Given this list of marker genes KRT71, DES, KRTAP9-7, KRTAP4-12, NCKIPSD, SYNM, BBLN, KRT39, KRT87P, VMAC, KRTAP4-5, KRTAP20-4, SAP30BP, PRKCE (protein kinase C epsilon), SYCE1L, HOXA13, GPER1, KRTAP23-1, DLGAP2, SMARCA2 (NCBI Gene Id 95083), KRTAP10-2, NARF, DSP, CLIP1, KRT23, KRTAP20-3, IFFO2, HLA-DRB1, KRTAP26-1, KRT31, PFDN5, KRT72, TLK2, KRTAP10-6, KRT86, SLC1A4, KRTAP12-1 (NCBI Gene Id 353332), KRT80, KRT12, S100A8, KRTAP5-2, KRTAP19-1, ING4, KRTAP20-1, KRTAP1-5, KRTAP5-5, SCYGR10, KRTAP4-11, KRTAP3-2, KRT14, KRT6A, KRT1, STN1, KRT40, KRTAP4-9, KRT75, NRP1, KRTAP4-2, SCYGR5, SCYGR2, RTN2, KRTAP22-2, SCYGR7, DYRK1A, KRTAP2-3, BCAS3, KRT73, KRT17, KRT18, SCYGR1, KRTAP21-3, MACF1, LMNB1, NR1I2, KRTAP1-4, KRTAP10-1, KRTAP9-6, KRTAP5-10, KRTAP20-2, RAD51, MNS1, KRTAP5-11, PHLDB2, KRT79, NEFM, EVPL, KRT2, KRT9, KRT78, KRTAP9-3, CSNK1A1, KRTAP19-4, KRTAP5-3, VIM, PRPH, KRTAP9-1, KRTAP25-1, KRTAP6-2, KRTAP5-6, KRTAP10-10, PKN2, SYNE2, DTNA, KRTAP13-2, KRT26, KRTAP8-1, DST, MICAL1, FBF1, KRT24, KRT36, KRTAP12-3, KRTAP19-8, KRT5, LDLRAP1, KRTAP10-3, EPPK1, KRTAP19-6, MMP14, KRTAP10-12, PADI6, KRTAP6-3, KRTAP1-3, KRT3, KRTAP2-4, MTRR, LMNA (lamin A/C), KRTAP13-4, NOL9, KRTAP19-5, NDOR1, KRTAP4-4, KRT33B, KRTAP9-9, KRT84, KRT77, CARMIL2, SLC1A6, KRTAP19-7, KRT76, KRTAP10-11, MDN1, KRT16 (NCBI Gene Id 3868), HSDL1, KRT83, KRTAP10-5, ZNF131, BFSP2, PNN, IFFO1, KRTAP3-1, ADORA2A, NDEL1, KRTAP4-16, KRT4 (keratin 4), KRTAP27-1, NEFH, GFAP, KRTAP19-2, KRT222, KRTAP24-1, KRT82, DDX60, KRTAP12-2, KRT19, KRTAP21-1, FAM83H, KRTAP12-4, SESTD1, SCYGR4, TCHP (trichoplein keratin filament binding), KRTAP19-3, KRTAP10-7, KRTAP17-1, KRTAP4-6, KRTAP22-1, KRTAP2-1, KRT13, KRTAP3-3, SYNC, KRTAP6-1, SCYGR9, KRT74, KRT81, KRTAP5-1, KRT85, KRT8, BFSP1, KRTAP7-1, KRTAP4-1, KRT34, KRTAP1-1 (NCBI Gene Id 95058), CASP14, KRTAP9-8, KRTAP9-2, KRTAP5-9, KRT6C, KRTAP5-4, KRTAP5-7, CLK3, KRT35, LMNB2, KRTAP10-8, KRT25, KRTAP9-4, PPL, JUP, CLDN11 (claudin 11), SCYGR6, KRT7, KRTAP13-3, KRT33A, SCYGR8, LMNTD1, KRTAP10-9, LMNTD2 (NCBI Gene Id 256329), SHANK2, PKP2, KRTAP5-8, KRT10, KRTAP16-1, NES, KRTAP15-1, DISC1, KRT15, KRTAP21-2, KRT28 (keratin 28), KRT6B, NEFL, EIF6 (eukaryotic translation initiation factor 6), KRTAP13-1, EXD2, KRTAP4-8, SCYGR3, KRT37, USP10, KRTAP10-4, PKP1, KRT32, KRTAP11-1, HTR2A, KRT20, KRTAP29-1, INA, UPP2, PLEC, KRTAP4-3, KRT38, KRT27, here is a description of the gene set: Human Gene Set: GOCC_INTERMEDIATE_FILAMENT_CYTOSKELETON studied in species Homo sapiens Cytoskeletal structure made from intermediate filaments, typically organized in the cytosol as an extended system that stretches from the nuclear envelope to the plasma membrane. Some intermediate filaments run parallel to the cell surface, while others traverse the cytosol; together they form an internal framework that helps support the shape and resilience of the cell.